The following is a description of a gene set: Any process that activates or increases the frequency, rate or extent of ligase activity, the catalysis of the ligation of two substances with concomitant breaking of a diphosphate linkage, usually in a nucleoside triphosphate. Human Gene Set: GOBP_POSITIVE_REGULATION_OF_LIGASE_ACTIVITY studied in species Homo sapiens, and this is the list of marker genes: ATPSCKMT, XRCC4, MID1IP1, NHEJ1, TMSB4X